Given this list of marker genes Lamc2, Lamb3, Lamc1, Megf9, Lamb2, Lama5, Lama3 (laminin, alpha 3), Ntn4, Lamb1, Pmp22 (peripheral myelin protein 22), Lama1, here is a description of the gene set: A large, extracellular glycoprotein complex composed of three different polypeptide chains, alpha, beta and gamma. Provides an integral part of the structural scaffolding of basement membranes. studied in species Mus musculus Mouse Gene Set: GOCC_LAMININ_COMPLEX